The following is a description of a gene set: species: Mus musculus A process in which a host organism activates or increases the frequency, rate or extent of the release of a process being mediated by a virus with which it is infected. Mouse Gene Set: GOBP_POSITIVE_REGULATION_BY_HOST_OF_VIRAL_PROCESS, and this is the list of marker genes: Tbc1d20, Hspa8, Zdhhc20, Apoe, Stom, Eef1a1 (eukaryotic translation elongation factor 1 alpha 1), Ppib, Nucks1, Vapb, Pik3c3, Pcx, Ythdc2, Csf1r, Ifng, Cav2, Paip1, Vapa, Cfl1, Zdhhc8, Igf2r, Zdhhc9, Zfyve1